The following is a description of a gene set: studied in species Homo sapiens Human Gene Set: HP_EXTRAHEPATIC_CHOLESTASIS Impairment of bile flow due to obstruction in large bile ducts outside the liver. Extrahepatic cholestasis, and this is the list of marker genes: TP53, KRAS, BRCA2, CDKN2A, CDKN1B, BRCA1, PALLD, PALB2, SMAD4, RABL3